Given this list of marker genes IGLC6, IGKV3-20, IGKC, IGLC3, JCHAIN, PIGR, IGLC1, IGHA1 (NCBI Gene Id 3493), IGHA2, IGLC7, here is a description of the gene set: Human Gene Set: GOCC_IGA_IMMUNOGLOBULIN_COMPLEX A protein complex composed of two identical immunoglobulin heavy chains of the IgA isotype and two identical immunoglobulin light chains, held together by disulfide bonds, and sometimes complexed with J chain or J chain and secretory component. An IgA immunoglobulin complex may be embedded in the plasma membrane or present in the extracellular space, in mucosal areas or other tissues, or circulating in the blood or lymph. species: Homo sapiens